Given this list of marker genes Lipa, Ccm2, Dll1, Flvcr2, Hey2, Notch1, Kdr, Tmem100, Rbpj, Prox1, Foxj2, Hey1, here is a description of the gene set: Mouse Gene Set: GOBP_BLOOD_VESSEL_ENDOTHELIAL_CELL_DIFFERENTIATION The process in which a relatively unspecialized cell acquires specialized features of a blood vessel endothelial cell, a thin flattened cell that lines the inside surfaces of blood vessels. species: Mus musculus